Given this list of marker genes Ago2, Ajuba, Trim71, Eif4g1 (NCBI Gene Id 320196), Ago1, Zfp36, Mir143, Mir135a-1 (microRNA 135a-1), Eif4enif1, Limd1, Wtip, Rbm4, Ago3, Mir186, Eif4e2, Mirlet7b, Mir875, Mir1247, Ddx6, Mir125a, Mir9-1, Eif6, Tnrc6b, Mirlet7g (NCBI Gene Id 387249), Ago4, Tnrc6a, Mir3960, here is a description of the gene set: Mouse Gene Set: GOBP_MIRNA_MEDIATED_GENE_SILENCING_BY_INHIBITION_OF_TRANSLATION species: Mus musculus An RNA interference pathway in which microRNAs (miRNAs) block the translation of target mRNAs into proteins. Once incorporated into a RNA-induced silencing complex (RISC), a miRNA will typically mediate repression of translation if the miRNA imperfectly base-pairs with the 3' untranslated regions of target mRNAs.